Given this list of marker genes Bach2 (NCBI Gene Id 319905), Ube3a, Nopchap1, Kmt2a, Unc5c, Ptpmt1, Mfsd12, Pdzd4, Caskin2, Nkain3, Tnfrsf19, 6430571L13Rik, Stox2, Daam2, Shld2, Fnbp1 (formin binding protein 1), Slc39a1, Large1, Sp6, Pced1a, Bcl2l15, Cercam, Cog5, Cdk14, Ublcp1, Klrb1f, Nr2c2, Ftmt, Slc16a10, Pak6, Plekhh1, Scarb2, Chd2, Kdm5b, Cnot6, Lancl3, Tbck, Parva, Fbxo30, Gm12250, Mapre1, Tifab, Arhgap1, Brdt, Klf11, Cdc42se2, Slc15a1, Senp1, Myo1c, Tmem169, S1pr1, Slc16a6, Tns3, Slc24a3, Pcyt1a, Asap1, Tlx2 (NCBI Gene Id 545897), Tmprss11a, Erbb4, Dkk4, Slc30a10, Grik4, Phc3, Hadha, Zbtb43, Mnat1, Kbtbd2, Ctsz, Strbp, Dnajc7, Septin8, Gpatch2l, Sos1, Adamts3, here is a description of the gene set: Mouse Gene Set: MIR_339_5P from publication Chen Y, Wang X (PMID 31504780) species: Mus musculus Genes predicted to be targets of miRBase v22 microRNA mmu_miR_339_5p in miRDB v6.0 with MirTarget v4 prediction scores > 80 (high confidence targets).